Given this list of marker genes POLG2, RAG2, PTEN, RET, CDKN2C, DUOXA2, MLH1, HRAS, TCF4, PRDM10, MSH6, TRHR, POLE, SAA1, SDHC, TPO, APC, TTC7A, SLC37A4, TCOF1, SIX5 (SIX homeobox 5), SRGAP1, SEC23B, MMP14, KCNJ18, SMARCE1, SMARCB1, GPR101, NF1, IYD, RRM2B, RCBTB1, CLCNKB, DICER1, POU1F1, NRAS, KAT6B, IRS4, GREM1, SUGCT, ALMS1, POLG, USF3, RPS20, MSH3, PMS2, DUOX2, SEMA4D, FOXN1, MST1, MSH2, PLCG2, AKT1, JAG1, HEPACAM, FOXI1, PIK3CA, NSDHL, PMS1, THRB, BRCA2, RAG1, HESX1, TG, NLRP1, PROP1, POLR1D (NCBI Gene Id 51082), FOXP3, HABP2, ARID2, ITCH (NCBI Gene Id 83737), LIG4, TSHB, PI4KA, CTLA4, SMARCC2, WRN, STAT1, SLC5A5, ZFAT, NFKB2, CASP10, C1S, TGFBR2, FOXE1, CHD7, IL7R, EPCAM, GLI3, SDHD, TBX2, LMNA, KMT2D, HLA-DQA1, MEN1, FAS, TSHR, AIP, SLC12A3, RMRP, LRBA, MDM2, ARID1A, LIFR (NCBI Gene Id 3977), ADA2, FASLG, MAD1L1, NDUFB11, LHX4, SIX1, EYA1, FLCN, IL2RA, CHEK2, MYT1L, ADAMTSL1, CACNA1S, DNAH1, MID1, SOX11, SOCS1, MINPP1, NKX2-5 (NCBI Gene Id 1482), SLC26A4, IL18BP, KCNJ10 (NCBI Gene Id 3766), ARID1B, LHX3 (LIM homeobox 3), GNB2, KEAP1, ATM, POLR1B, CDKN1A, POLR1C, SMARCA4, SEMA4A, MUTYH, DPF2, PAX8, NKX2-1, SLC25A4, SASH1, IDH1, POLD1, PDE11A, GNAS, PRKAR1A (protein kinase cAMP-dependent type I regulatory subunit alpha), SDHB, KRAS, MMP2, CDKN2B, STAT5B, CDKN2A, KLLN, FOXD3, TP53, DCLRE1C, IDH2, SOX4, TWNK, CDH23, SMARCD1, BMPR1A, CCBE1, HLA-DQB1, CDC73, ADA, CDKN1B, GPR35, IL2RG, here is a description of the gene set: A structural abnormality of the thyroid gland. Human Gene Set: HP_ABNORMAL_THYROID_MORPHOLOGY Abnormal thyroid morphology species: Homo sapiens